The following is a description of a gene set: species: Homo sapiens from publication Zheng S, Papalexi E, Butler A, Stephenson W, Satija R (PMID 29545397) Human Gene Set: ZHENG_CORD_BLOOD_C10_MULTILYMPHOID_PROGENITOR, and this is the list of marker genes: SH3TC1, HCST, S100Z, IQGAP2, CARD11, AFF1, JCHAIN, LINC00865 (long intergenic non-protein coding RNA 865), CYTH4, SYK, MAP1A, LZTFL1, FGD6, SH2D3C, SLC2A5, ARRB2, NEGR1, ARHGAP25, CD74, SCN3A, ARHGEF7, ITM2C (NCBI Gene Id 9523), RBM38 (NCBI Gene Id 55544), CARD19, SATB1, CLNK, ACY3 (aminoacylase 3), LPIN1, STARD9, LUC7L3, BAALC, RBM17, QPRT, BTK, LINC00426, CYTH1, CD52, CXXC5, LAIR1 (leukocyte associated immunoglobulin like receptor 1, NCBI Gene Id 3903), VSIR, COBLL1, MEF2A, NHERF1, TYROBP, RERE, IGHM, SETBP1, MZB1, C9orf78, RAB31, JAML, ADA, ITGAL, PAG1, PRKCB, COL24A1, GSTP1, ACTG1, USP36, NIN, TRAF3IP3, PACSIN1, MALAT1, CD47, DDX17, LINC00173, RNASET2, PREX1, SASH3, IL6R, IRF8 (NCBI Gene Id 3394), LTB, RSRP1, NCOA7, ACAP2, DSTN, PRAM1, EVL, TNFAIP2, SPINK2, ARL6IP5, GFOD1, LST1, PIK3R1, MME, MED13L, KCNK17, CORO1A, OSBPL3, CD99, KIAA0087, TRBC2, FAM30A, SPNS3, ARPC5L, TTC3, CYFIP2 (cytoplasmic FMR1 interacting protein 2)